Given this list of marker genes H4C1, H4C15, H2AC8, H4C13, H4C9, H4C3, H4C4, H2AC4, H4C16, H4C14, H4C6, H4C11, H4C8, H4C5, H4C2 (H4 clustered histone 2), CENPA, H2BC11, H4C12, here is a description of the gene set: Human Gene Set: GOBP_PROTEIN_LOCALIZATION_TO_CENP_A_CONTAINING_CHROMATIN studied in species Homo sapiens Any process in which a protein is transported to, or maintained at, CENP-A containing chromatin.